The following is a description of a gene set: studied in species Homo sapiens Genes having at least one occurrence of the motif GGAAAWT in the regions spanning 4 kb centered on their transcription starting sites. This matches the HMGA1 transcription factor binding site V$HMGIY_Q6 (v7.4 TRANSFAC). Human Gene Set: HMGIY_Q6, and this is the list of marker genes: FOXP1, CD40, MEF2D, JPT2, HCN3, ERG, RELA (RELA proto-oncogene, NF-kB subunit, NCBI Gene Id 5970), DUSP6, WNT9B, PRR11, B4GALT5, NID2, MDH1, NDRG2, PAFAH1B1, NPHP4, TERT, NEPRO, NDUFS1, ECEL1, NFATC4, STIP1, SP7, POLD3, NDUFA4L2, SLITRK1, WNT10A, CDC27, IRX5, FOXB1, KLRC3, LMO3, HOXB4, SRR, NLK, PTGIR (prostaglandin I2 receptor), KCTD15, TMEM81, GAD1, HOXB8, B3GNT7, PTHLH, HECTD2, STK32C, PITX2, NMU, CAMSAP2, BCL6, VGLL4, MAPK4, UBE2E2, PHOX2B, EEF1B2, SLC6A12, FGF10, PEX5L, PLXDC2, MAML2, TFAP2C, F13B, C1orf21, BICDL1, AOC3, LINC00470, OBSCN (NCBI Gene Id 84033), TNFSF11, IL1RN, SCAMP1, STX16, DOC2B, ONECUT1, IKZF3, NXPH4, MOCOS (NCBI Gene Id 55034), MYBPC1, RBPJ, KLF5, AAK1, NEURL1, PTMS, ST8SIA1, TP63, ZIC4, RNF43, IFT80, FXYD2 (FXYD domain containing ion transport regulator 2), TAFAZZIN, ARL17A, FASTKD2, LRRTM4 (NCBI Gene Id 80059), NIBAN1 (NCBI Gene Id 63911), RAB34, LIF, HNRNPC, FEV, RPL23A (ribosomal protein L23a), TGM7, CADM1, FGF8, IL16, RFTN2, UBR3, KRT8P41, RIN2, BTBD10, RASAL2, STMN1, POU2F1, KLRC2, CNTN4, PTPN22, TSC22D1, SKA2 (NCBI Gene Id 348235), GRIK1, INSM1, CD180, PRRG4, ETV3, BRINP3, ZMYND8, MLLT11 (NCBI Gene Id 149430), SOX5, MAP2K3, DCHS2, HOXC4, NFIX, GPR65, NFKBIA (NCBI Gene Id 4792), MGLL, IL22, MON1A, CHRNA9, KCNH7, ZIC1, LINC00173, SMG6, MSX1, OSMR, WAC, MBNL1, ARL3, GEN1, KCNAB1, IL18RAP, PDE4C, COPS7A, GPR171, NEDD4L, ZPBP2, ANKRD12, MRC2, HTR3B, SLC7A1, C1orf116, MIR17HG, FAM117A, SHISA6, HOXB6, BATF, MEIS1, PPM1B, NOS1, PDE4D, CALCRL, MIA, KLRC1, CDC42SE1, TAF5, LINC00898, VAMP3, SH3BGR, DLL3, CNKSR1, IGF2BP1, ZNF675 (zinc finger protein 675), MAPK6, ICAM1, LEMD1, CNIH2, TEX2, IL24 (interleukin 24), EVA1B, TMPRSS3, IKZF2, HOXC6, TACC2 (transforming acidic coiled-coil containing protein 2), LYVE1, PLAGL2, OTP, CAMKV, NCAM1, MAP2K6 (mitogen-activated protein kinase kinase 6), RRM1, TNFSF4, C1orf54, POFUT1, ESM1, REM2, MAB21L1 (mab-21 like 1), KLRA1P, PPP2R3A, ANKRD11, HSPG2, ATP1B3, SFXN2, ARHGAP15, MAP3K8, MIER3, PCDH10, EN1 (NCBI Gene Id 2019), LMO4, GAS7, CAPZA3, NR4A2 (nuclear receptor subfamily 4 group A member 2), DONSON, USP2, PRICKLE1, PAN2, HNF1A, TNFSF18, ZNF654, C19orf18, RNF220, KLKB1, ZNF263, NTRK3 (neurotrophic receptor tyrosine kinase 3), AMOTL1, CSF3, TIAL1, EIF1, KRT72, KLK9, ARL4C, CXCL10, HAPLN2, TM6SF1, SMC6, SMC4, EIF4G1, SLC1A7, CATSPERB, BCL11A, VIT, FAM98A, ANKRD28, ATP5MC2, CTNND1, RNF26, VN1R3, PI4K2A, VAC14, PNKD, PTBP2